Given this list of marker genes CAMK1, CAMK1D, CALM2, CAMK2B, CALM3, CAMK2D (calcium/calmodulin dependent protein kinase II delta), CAMK2G, CAMK2A, CALM1, PLCG2, PLCG1, CAMK1G, EGFR, CAMK4, here is a description of the gene set: Pathway Definition from KEGG: EGFR* -> PLCG -> IP3 -> Ca2+ -> CALM == CAMK species: Homo sapiens Amplified EGFR to PLCG-CAMK signaling pathway. Pathway ID: N00027. Pathway type: Variant. Pathway class: nt06273 Glioma. Human Gene Set: KEGG_MEDICUS_VARIANT_AMPLIFIED_EGFR_TO_PLCG_CAMK_SIGNALING_PATHWAY